The following is a description of a gene set: Reactome Pathway: Condensation of Prometaphase Chromosomes This event has been computationally inferred from an event that has been demonstrated in another species.<p>The inference is based on the homology mapping from PANTHER. Briefly, reactions for which all involved PhysicalEntities (in input, output and catalyst) have a mapped orthologue/paralogue (for complexes at least 75% of components must have a mapping) are inferred to the other species. electronically inferred by orthology from the curated human pathway species: Mus musculus part of: Mitotic Prometaphase, and this is the list of marker genes: Csnk2b, Ncaph